Given this list of marker genes Ifi207, Gbp5, Phf11b, Ifi205, Parp9, Ifit3, Ifi213, Ms4a4c, Ifitm3, Ccl12, Mndal, Sp110, Stat1, Lgals9, Samhd1, Stat2, Oas3, Phf11d, Themis2, Cxcl10, Ifi203, Oas1a, Parp12, Sp100, Plekho2, Ifih1, Smchd1, Mlkl (mixed lineage kinase domain-like), Slfn8, Gch1, Herc6, Ube2l6, Psmb9, Zup1, Slfn5, Fcgr1, Scimp, Ifi204, Xaf1, Aida, Ifi211, Trim30a, Pnp, Ifi209, Mx1, Ifi206, Ifit2, Eif2ak2, Rsad2, Isg15, Dhx58, Isg20, Cxcl9 (C-X-C motif chemokine ligand 9), Map2k1, Ccl2, Nt5c3, Igtp, Rtp4, Rigi, Psmb10, Irf7, Serpina3g, Oasl2, Serpina3f, Cmpk2, Zbp1, Ifi47, Gnb4, here is a description of the gene set: species: Mus musculus from publication Cui A, Huang T, Li S, Ma A, Pérez JL, Sander C, Keskin DB, Wu CJ, Fraenkel E, Hacohen N (PMID 38057668) Genes positively differentially expressed in cell type: Macrophage upon treatment with cytokine: IFN-κ in mouse lymph nodes in vivo. Cytokines mediate cell-cell communication in the immune system and represent important therapeutic targets. A myriad of studies have highlighted their central role in immune function, yet we lack a global view of the cellular responses of each immune cell type to each cytokine. To address this gap, the authors created the Immune Dictionary, a compendium of single-cell transcriptomic profiles of more than 17 immune cell types in response to each of 86 cytokines (>1,400 cytokine-cell type combinations) in mouse lymph nodes in vivo. A cytokine-centric view of the dictionary revealed that most cytokines induce highly cell-type-specific responses. For example, the inflammatory cytokine interleukin-1β induces distinct gene programmes in almost every cell type. A cell-type-centric view of the dictionary identified more than 66 cytokine-driven cellular polarization states across immune cell types, including previously uncharacterized states such as an interleukin-18-induced polyfunctional natural killer cell state. Mouse Gene Set: CUI_MACROPHAGE_IFNK_RESPONSE_UP